The following is a description of a gene set: Human Gene Set: HP_NIGHT_SWEATS Occurrence of excessive sweating during sleep. Night sweats studied in species Homo sapiens, and this is the list of marker genes: HLA-DRB1, GPR101, JAG1, STAT6, CD28, BCL2, AIP, MLX, TNFRSF1B, SLC25A13, NAB2, CTLA4, SDHD, IFNGR1, BCL6, IL12B (NCBI Gene Id 7907), UBA1, TSPOAP1, TH, HLA-B